The following is a description of a gene set: Genes predicted to be targets of miRBase v22 microRNA mmu_miR_7040_3p in miRDB v6.0 with MirTarget v4 prediction scores > 80 (high confidence targets). Mouse Gene Set: MIR_7040_3P from publication Chen Y, Wang X (PMID 31504780) studied in species Mus musculus, and this is the list of marker genes: Ints12, Ugt1a10, Arhgap35, Mmp16, Ugt1a5, Nr4a2, Cpne2, Brix1, Hdac9, Kynu, Rabl2, Dido1, Rnf185, Prdm4, Psg16, Iigp1c, Ptpn1, Palld, Pramel60, Gpr158, Rab14, Sox12 (SRY (sex determining region Y)-box 12), Prrt4, Fbxw8, Ugt1a7c, Wdr37, Abl1, Ugt1a6b (UDP glucuronosyltransferase 1 family, polypeptide A6B), Ugt1a2, Ugt1a1, Srcap, Wasl, Adcy1, Rasgrp2, Mrap2, Usp7, Klhl31, Fgd2 (NCBI Gene Id 26382), Ugt1a9, Ssr3, Tll1, Tbx4, Rhoa, Cd81, Ugt1a6a, Acox3, Ebi3, 4931406C07Rik